The following is a description of a gene set: studied in species Homo sapiens Human Gene Set: GOBP_MITOTIC_SISTER_CHROMATID_SEPARATION The process in which sister chromatids are physically detached from each other during mitosis., and this is the list of marker genes: CDC20, ESPL1, RB1, KNTC1, NUF2, BUB1, RAD21, LCMT1, ANAPC11, IK, MAD2L2, KLHL22, KNL1, SPDL1, CENPF, FBXO5, TRIP13, ZWINT, SPC24, MAD2L1BP, INCENP, CDC16, PLK1, DLGAP5, ANAPC5, ANAPC15, PSMG2, MAD2L1, PRP4K, SPC25 (NCBI Gene Id 57405), PRAP1, AURKB, GEN1, CDK5RAP2, ATM, NDC80, TTK (TTK protein kinase), ANAPC7, SKA1, ZNF207, CCNB1, PPP2R1A, MAD1L1, ZWILCH, USP44, CUL3, ZW10, UBE2C, NCAPH2, APC, DIS3L2, XRCC3, BUB3, TPR, BUB1B, DYNC1LI1, CDCA8, TEX14, BIRC5, DUSP1, SKA3, NSMCE2, HASPIN, CDC23